The following is a description of a gene set: studied in species Homo sapiens Any process that modulates the occurrence or rate of T cell death by apoptotic process. Human Gene Set: GOBP_REGULATION_OF_T_CELL_APOPTOTIC_PROCESS, and this is the list of marker genes: PRELID1, BBC3, LGALS9, CD274, DOCK8, IDO1, BCL2, PDCD1, PRKCQ, PRKD2, FADD, GPAM, ST3GAL1, HIF1A, TP53, BCL2L11, ZC3H8 (NCBI Gene Id 84524), BCL3, KIFAP3 (NCBI Gene Id 22920), ARG2, RAG1, PERP, CCL5, ADAM8, EFNA1, ADA (adenosine deaminase), RIPK3, RORC, BMP4, WNT5A (Wnt family member 5A), PIP, SLC46A2, TSC22D3, CD27, LGALS16, IL7R, P2RX7, TGFB2, LGALS3, GIMAP8, BCL11B, JAK3, PTCRA